The following is a description of a gene set: Any process that modulates the frequency, rate or extent of protein localization to synapse. Mouse Gene Set: GOBP_REGULATION_OF_PROTEIN_LOCALIZATION_TO_SYNAPSE species: Mus musculus, and this is the list of marker genes: Hras, Nlgn1, Gripap1, Map2k1, Dlg1, Gpc4, Nlgn2, Gsk3b, Mapt, Prkcz, Vps26b, Nbea, Nlgn3, Traf6, Gabarap, Cacna2d2, Tmem108, Kif2c, Abhd17b, Arhgap44, Kalrn (kalirin, RhoGEF kinase), Tnik, Rap1a, Clstn3, Iqsec2, Neto2, Ghsr, Camk2a, Magi2, Ogt, Dag1, Adam10, Rapgef4, Gpc6